The following is a description of a gene set: Small membrane-bounded organelle formed by pinching off of a coated region of membrane. Some coats are made of clathrin, whereas others are made from other proteins. species: Homo sapiens Human Gene Set: GOCC_COATED_VESICLE, and this is the list of marker genes: HLA-E, IGF2R, BTC, HLA-DQB2, AP3B2, MYO1E, COPZ2 (NCBI Gene Id 51226), ERGIC3, HLA-DRB1, HLA-DRA, RAB5A, AFTPH, SEC24D, STEAP2, PIK3C2A, CLVS2, SEC16B, HLA-DPB1, ATP6V1G2, AP1S1, HLA-DRB5, RAB27B, VPS33B, DENND1C, EPN2, TMED3, DDHD2, PACS1, CPNE6, EPN1, EPGN, CLBA1, ECPAS, EDN1, AAK1, CIDEB, LMAN2, ATP6AP2 (ATPase H+ transporting accessory protein 2), AP2M1, MYO6, LDLRAP1, TEPSIN, M6PR, OCRL, ATP6AP1, RAB3A, SFTA3, SEC16A, ASTN2 (astrotactin 2), ATP6V1F, HLA-DQA2, GOLGA2, COPB2 (NCBI Gene Id 9276), LMAN2L, GPR107, F5, SCYL2, CD9, CTSC, BNIP1, ARCN1, CTLA4, ARC, TMED6, ABCB4, SFTPC, STON1, NRGN, USE1, REEP6, HEATR5B, CLTC, SLC28A2, HLA-F, TMED2, SFTPB, TGFA, SFTPA1, COPA (NCBI Gene Id 1314), HLA-A, ATP6V0B, STX6, SNX18, SNAP91, KLHL12, CNIH3, SLC17A7, ATP6V0A1, YIPF5, VPS33A, ROR2, SEC24A, COL7A1, NECAP2, COPZ1, KDELR2, HLA-B, CD3D, STX17, SREBF2, LMAN1L, CCDC115, ATP6V1E1, CRYZL2P-SEC16B (NCBI Gene Id 111240474), YIPF6, AP3B1, PACSIN1, TNK2, ATP6V0C, SEC23IP, VAMP3, CEMIP, TMEM199, KIAA0319, FOLR1, SEC31B, CLTA, RNF216, SNX3, CD3G, GRIA1, SCAP, DVL2, GAS7, VPS18, VAMP4, SLC2A8, SORT1, SEC24C, APOB, SREBF1, AVP, AP4B1, CTSZ, SEC13, HAX1, AP1B1, SEC31A, CNIH2, VAMP8, RAB13, F8, KDELR1, RAB12, CNIH1, SYT1, AVPR2, SEC23B, NCALD, ATP6V1B2, APOLD1, COPE, TMED5, VPS41, ATP6V1C1, HLA-DQA1, CRACR2A, TMED9, ERGIC2, VTI1A, SGIP1, YIF1B, DAB2, TEX261, B2M, WIPI1, RAB14, MCFD2, PHETA1, SPG21, VMA21, ATP7A, RAB8A, VWF, EGFR, GOPC, VAMP7, AP1G2, SYT11, SEC23A, ADCY8, SNX9, DIPK2A, NECAP1, TFRC, KDELR3, ASTN1, IL7R, DENND1A, ATP6V1A, HLA-H, CD59 (NCBI Gene Id 966), AP1S3, ENTHD1, VAMP2, AP1M2, LMBRD1, HLA-DRB4, SFTPD (surfactant protein D), EPS15, COPG2, INPP5F, HLA-C, TMED7, VTI1B, DBNL, CD207 (CD207 molecule), FCGR1A, ATP6V1D, COPG1, TMED1, CLRN1, SCARB2, ECE1, LRP2 (LDL receptor related protein 2), CD4, CLVS1, AP2A2, WNT5A, GOSR2, TF, SH3BP4, GAD1, AP1S2, AP2A1, PICALM, EGF, DNAJC6, TYRP1, ATP6V0E2, STX5, SH3GL2, HIP1, MALL, SEC22B, VANGL2, RASSF9, FZD5, TMED4 (transmembrane p24 trafficking protein 4), DNAJC5, HLA-DQB1, CLTCL1, TMED10, SERPINA1, CHRM2, SAR1B, ADRB2, CFTR, GAK, PANK1, HSPD1, SYT9, GAD2, SAR1A, ERGIC1 (endoplasmic reticulum-golgi intermediate compartment 1), SLC32A1, BTBD8, DNM2, SLC18A2, SLC18A1, ADAM10, SFTPA2, NUMB, AP2S1, COPB1, LDLR, ATP6V1H, CNIH4, SLC30A5, TGOLN2, PDCD6, SLC18A3, FCGR1BP, EPN3, MLC1, HBEGF, SCAMP1, BCAP31, AP1M1, CLTB, RAB8B, HSPA8, AREG, DENND1B, FZD4, IER3IP1 (immediate early response 3 interacting protein 1), LMAN1, UNC13D, CD74, DVL1, SLC2A4, VPS11, RNASEK, STON2, PCSK9, MYCBPAP, CLINT1, PHETA2, RAB35, FURIN, SCYL1, SYT2, SURF4, SEC24B (SEC24 homolog B, COPII coat complex component, NCBI Gene Id 10427), AP1G1, EREG, VPS16, FCHO1, YIF1A, TBC1D5, FZD2, APOE, FCHO2, AP2B1 (NCBI Gene Id 163), HLA-DPA1, HIP1R, PEF1, GGA2, SYNRG, RAB27A, ATP6V0D1, HLA-DRB3, HLA-G, USO1